The following is a description of a gene set: The expansion of a CD4-positive, alpha-beta T cell population by cell division. Human Gene Set: GOBP_CD4_POSITIVE_ALPHA_BETA_T_CELL_PROLIFERATION species: Homo sapiens, and this is the list of marker genes: CD3E, LGALS9C, ARG2, XCL1, CBLB, LGALS9B, NDFIP1, CD55, IL2RA, CD28, CD81, RIPK2, FOXP3, IL2, TGFBR2, CARD11 (caspase recruitment domain family member 11), LGALS9, PRKCQ, TWSG1, CD274, VSIR, ITCH